The following is a description of a gene set: species: Homo sapiens Human Gene Set: MIR4518 from publication Chen Y, Wang X (PMID 31504780) Genes predicted to be targets of miRBase v22 microRNA hsa-miR-4518 in miRDB v6.0 with MirTarget v4 prediction scores > 80 (high confidence targets)., and this is the list of marker genes: PBX1, DPYSL3, MITF, DIAPH1, CSRNP1, WAPL, SLC35C1, E2F7, CFAP53, MKRN1 (NCBI Gene Id 392799), MYO18A, NCOR1, ANAPC11, AFG1L, ADGRF2P, GPSM3, PKLR (pyruvate kinase L/R), PRORP, KLHL12, TRIP13, INSYN2B, CCDC15, PRIMA1 (proline rich membrane anchor 1), ASB7, PI4KB, ARHGEF40, AMER1, SYNPO2 (synaptopodin 2), ZXDC, ERGIC2, SLC25A36, MINDY1, EPB41L5, STARD13, TMEM201, PSIP1, BTBD7, LRRC10B, LRRC20, LZTS1 (leucine zipper tumor suppressor 1), MAPRE1 (microtubule associated protein RP/EB family member 1), GIPC3, NAA20, TET3, NKD1, THRB, PRX, DDX42, NTMT1, LHX6, CS, BTN2A2, ASTN1, LILRB4, PHF13, FAM168A, WDR33, GPX3, C10orf105, TMEM101, TSGA10, BPIFB2, SV2B, PRMT5, DCLRE1C, PAK1IP1, TGFA, PROM2, OAS1, SLC25A44, KCNB1, MATR3, CLIP3, LINC03040, NR2C2AP, OLIG2, IP6K2, SLC13A3, APTX, CAPZB, ARID1A, TTPAL, KIF18A, ZNF732, FRMPD1, GALNT12, WIPF1, KCNK10, SLC2A1, TENT4A (NCBI Gene Id 11044), CDCA8, ZKSCAN1